Given this list of marker genes GRM3, HOXA6, GDNF, PSMA1, NDST4, PDE3B, RNF115, EGFLAM, HSPB6, LAMP5, CTTNBP2NL, SLCO1C1, KMT2A, PTGDR2, KLF10, IKZF2, FSTL1, NFAM1, TNR, SOX21, WNT2B, ALS2, KDM3B, OMA1 (OMA1 zinc metallopeptidase), TSC22D3, NAV2, HIP1R, IGF1, ZFHX3, RAB8A (RAB8A, member RAS oncogene family), ADGRF3, MEOX2, WBP2NL, TFAP4 (NCBI Gene Id 7023), UBE2W, OTX2, CHMP2A, MYO18A, PALS2, FGFR2, HOXB8, GGNBP2, FOXA1, TMEM196, UBE2K, XPNPEP2, BMX, PITX2, NR2E1, XRCC1, HAPLN1, MRPS18C, CMKLR1, NOTCH4, TCERG1L, MID2, CSNK1A1, FGF12, PDC, LRMDA, TBR1, CLCN5, PHF1, RORC, KPNA4, STK40, HOXA2, ROBO4, ST8SIA1, CRYGD, ZMAT3, GSE1, POLR3C, ATP6V1A, CREBZF, SEC16B (NCBI Gene Id 89866), DMD, APOBR, PPP2R5D, RTL9, PIK3R3, PTH1R, MASP1, PFN2 (NCBI Gene Id 85837), DIDO1, ELL, NXF3, C1QTNF4 (C1q and TNF related 4), LGI1, CLTC, SIRT1, PROSER3, NUFIP2, ALKBH5, MSTN, CPLANE2, RALYL, PCMTD1, STC2, RAB5C, LMO1, TMEM62, PPARG, PDP1, FAP, DHH, RPLP0, ACVR1, NOL4L, SPTLC2, HSD3B7, CASKIN1, ROGDI, NAA50, ZFP91, KIRREL3, QRFP, ZEB2, LIF, DDX25, MYB, here is a description of the gene set: from publication Xie X, Lu J, Kulbokas EJ, Golub TR, Mootha V, Lindblad-Toh K, Lander ES, Kellis M (PMID 15735639) Human Gene Set: AGCYRWTTC_UNKNOWN Genes having at least one occurrence of the highly conserved motif M135 AGCYRWTTC in the regions spanning 4 kb centered on their transcription starting sites. The motif does not match any known transcription factor binding site. Comprehensive identification of all functional elements encoded in the human genome is a fundamental need in biomedical research. Here, we present a comparative analysis of the human, mouse, rat and dog genomes to create a systematic catalogue of common regulatory motifs in promoters and 3' untranslated regions (3' UTRs). The promoter analysis yields 174 candidate motifs, including most previously known transcription-factor binding sites and 105 new motifs. The 3'-UTR analysis yields 106 motifs likely to be involved in post-transcriptional regulation. Nearly one-half are associated with microRNAs (miRNAs), leading to the discovery of many new miRNA genes and their likely target genes. Our results suggest that previous estimates of the number of human miRNA genes were low, and that miRNAs regulate at least 20% of human genes. The overall results provide a systematic view of gene regulation in the human, which will be refined as additional mammalian genomes become available. studied in species Homo sapiens